Given this list of marker genes KREMEN1, KREMEN2, LRP5, DKK1, DKK2, DKK4, here is a description of the gene set: Signaling by LRP5 mutants studied in species Homo sapiens Human Gene Set: REACTOME_SIGNALING_BY_LRP5_MUTANTS